The following is a description of a gene set: Molybdenum cofactor (Moco) biosynthesis species: Homo sapiens Human Gene Set: WP_MOLYBDENUM_COFACTOR_MOCO_BIOSYNTHESIS, and this is the list of marker genes: SUOX, MOCS2, MTARC2, MOCS1, AOX1, GPHN, XDH